The following is a description of a gene set: species: Mus musculus Mechanisms regulating self-renewal and cell fate decisions in mammalian stem cells are poorly understood. We determined global gene expression profiles for mouse and human hematopoietic stem cells and other stages of the hematopoietic hierarchy. Murine and human hematopoietic stem cells share a number of expressed gene products, which define key conserved regulatory pathways in this developmental system. Moreover, in the mouse, a portion of the genetic program of hematopoietic stem cells is shared with embryonic and neural stem cells. This overlapping set of gene products represents a molecular signature of stem cells. Genes in the expression cluster 'MBC Shared': up-regulated in mature blood cell populations from adult bone marrow and fetal liver. Human Gene Set: IVANOVA_HEMATOPOIESIS_MATURE_CELL from publication Ivanova NB, Dimos JT, Schaniel C, Hackney JA, Moore KA, Lemischka IR (PMID 12228721), and this is the list of marker genes: EPS15, DGKH, MTF1, FGR, CDCA3, BPGM, HEBP1, STAB2, COLEC12, BMPR1A, ADGRE1, MRPL53, GRIPAP1, XPO7, TAPT1, HYCC1, CDK8, MREG, ADD1, P2RY13, GOLIM4, IFT80, TCP10L, TMEM9B, AP2A2, SPTA1, SLC7A8, PTDSS2, STX11, LIMS1, ATP6V0A1, AAK1, MFSD14B, LNPK, PGLYRP1, COL1A1, ACP1, LBR, PLCB1, NOCT, FAM210B, LGMN, MPP1, SDCBP, LAMP2, USP32, ASNS, HSPA4L, WDR26, CTSH, STX17 (NCBI Gene Id 9485), MARCHF2, IFIT1B, MOSPD1, ITGAM, SYAP1, NHSL2, WFDC21P, TRIM56, SUPT4H1, OTUD5, CD14, TNRC6B, TCEA1, STMP1, NAT9, ARHGAP19, RBMS1, SH3TC2 (SH3 domain and tetratricopeptide repeats 2), IL33, RAB11FIP4, THBS1, UBLCP1, RNF141, TMEM170A, RAB43, C3, ABCA13, HEMGN, USP25, COPS3, ANKRD9, RHAG, MXD1, SCRN3, GAPVD1, FPR1, MINDY2, ACSL1, M1AP, CTSB, ETFRF1 (electron transfer flavoprotein regulatory factor 1), KDM7A, CIR1 (NCBI Gene Id 9541), ADGRE4P, C15orf48, PPOX, SLC25A38, CDC42EP3, WIPI1, RBFOX3, ZNF740, RNASE3, CD226, DIO3OS, LILRB1, SRI, TCP11L2, SLC16A1, ADIPOR1, GRINA, KLF11, SLK, C1QB, PRPF18, SPTB, CCNA2, SOWAHA, MAP4K5, BMP2K, LRRC28, SERTAD3, AMPD3, PLBD1, C1GALT1, AGFG1, SLC40A1, LMTK2, GUCD1, SLC66A2, SLC66A3, TRAK2 (NCBI Gene Id 66008), OTUB2, AP5S1, HGSNAT, ABCB6, NAAA, BNIP3L, SNCA, TM4SF4, PIK3CB, PLA2G2F, RAB6A, C1S (NCBI Gene Id 716), SERTAD2, SERINC5, KLF3, MKRN1, SLC25A37, CLIC6, GPCPD1, MCUB, HACE1, ITGB2, TSPAN17, NINL, CDKN2D, TMPO, SLC30A10 (NCBI Gene Id 55532), DCK, RNF19A, TLCD4, E2F2, RIOK3, PC, SPECC1, HECTD1, EGFR, FPR2, PITHD1, CCND3, ARL2BP, BTNL10P, DAAM1, PPP3R1, ANO10, TRIM59, RNF167, ENDOD1, SACM1L, TMCC1, ACTA2, EIF5A2 (eukaryotic translation initiation factor 5A2), SLC11A1, GTPBP2, UPB1, PI4K2B, TPRG1L, PRC1, SCD, RHD, GPATCH1, ALAS2, CLDN4, NR3C1, MMP8, MOB2 (MOB kinase activator 2), MTHFD2, CCP110, TMEM255A, MACIR, SLC22A23, SPDL1, GADD45A, CAST, G2E3, INTS6L, YPEL5, MXI1, DEDD2, CMAHP, FAM220A, MRC1, ST3GAL5, CELA1, FN3K, CYBB, CDR2, TSPAN8, ADGRL3, TRIM48, CES1, SLC4A1, USP7, SLC25A44, ST3GAL6, RAB24, LYVE1, TMX1 (thioredoxin related transmembrane protein 1), NXPE2, RFFL, SLFN12, TFDP2, GYPA, RMC1, STX2, SNX13, EPOR, ARL6IP1, CPEB4, SGO2, MARCHF8, KEL, CDKN3, STK17B, C3orf62, LRG1, MTSS1, FBXO34, SLC1A5, SMIM5, GABPB2 (GA binding protein transcription factor subunit beta 2), TMCC2, MGST3, RELCH, HERPUD2, GTF2A1, ERGIC2, ATP8A1, SYNJ1, DCAF10, NUDT4, PICALM, PAQR9, USP46, DEGS1, CPD, PPBP, HAGH, PIGQ, C4orf3, ATP6V1E1 (ATPase H+ transporting V1 subunit E1), SMOX, NIPA2, GCNT1, DERL2, C11orf24 (NCBI Gene Id 53838), LPCAT1, ZBBX, CMTR1, TENT5C, ATG4A, HTATIP2 (HIV-1 Tat interactive protein 2), STRADB, GPX4, ACP5, TLR6, UBAC1, LAMP1, RAD51C, CMAS, CHP1, TBCEL, EHBP1L1